The following is a description of a gene set: studied in species Homo sapiens Human Gene Set: GOMF_VITAMIN_TRANSMEMBRANE_TRANSPORTER_ACTIVITY Enables the transfer of a vitamin from one side of a membrane to the other., and this is the list of marker genes: RBP4, SLC2A1, SLC2A6, SLC25A19 (solute carrier family 25 member 19), ABCD4, SLC23A2, SLC19A2, GC, SLC47A1, SLC19A4P, ABCA4, SLC25A32 (NCBI Gene Id 81034), SLC22A2, SLC46A1, SLC2A14, ABCG2, SLC27A1, SLC23A1, SLC2A2, SLC19A3, ABCC1, SLC52A3, SLC22A1, SLC44A4, SLC5A6, SLC52A1 (solute carrier family 52 member 1), SLC2A10, PDPN, SLC2A8, RTBDN, SLC52A2, SLC19A1, STRA6, SLC2A3, SLC22A14